The following is a description of a gene set: species: Homo sapiens Human Gene Set: GOBP_POSITIVE_REGULATION_OF_TRANSMEMBRANE_TRANSPORT Any process that activates or increases the frequency, rate or extent of the directed movement of a solute from one side of a membrane to the other., and this is the list of marker genes: LCN2, ABL1, SLC7A5, PLA2G1B, IL13, KCNE5, PSEN1, CAPN10, CRACR2A, CLTRN, RNASEL, ATP1B2, JPH2, XCL1, PPP3R1, C2CD5, HTT, INS, ERFE, EDN1, APPL1, STK39 (serine/threonine kinase 39), IRS2, ACSL5, GRIN1, C3, OPRK1, FGF19, KCNJ2, ARL6IP1, LRRC26, F2R, CD19, STIMATE, P2RX5, CFTR, NR4A3 (NCBI Gene Id 8013), ADIPOQ, OSBPL8, KCNE1, FGF13, AZIN2, NOS1, IFNG, PLCG1, ATP2A1, SLC26A6, CXCL9, CAPN3, CA2, PTPRM, GH1, LRRC52, CREBL2, F2RL3 (F2R like thrombin or trypsin receptor 3), OPN3, F2, NIPSNAP2, BDKRB1, ITGB1 (NCBI Gene Id 3688), SORBS1, MIR1-1, FHL1, FXYD7, ATP1B1, MIR210, ITLN1, ZDHHC7, POU4F2, FXYD5, SLC1A2, WNK3, TOR2A, PPP3CB, EDNRA, CXCL10, ATP1B3, P2RX1, AKAP7, ADCYAP1R1, KLF15, CXCR3, P2RX4, CTSS, RHOQ, PDPK1, FXYD6, TRPC1, NOS1AP (nitric oxide synthase 1 adaptor protein), IGF1, STIM2, AKT2, ARPP19, PPP3CC, CASQ1, IRS1, TRPC3, SNCA, EDN3, HEPH, VMP1, FXYD1, THY1, GPER1, KCNIP2, CLTCL1, CX3CL1, C1QTNF12, ATPSCKMT, P2RX7, TMSB4X, RAP1A, COX17, FXYD4, INSR, ANK2, STAC3, LRRC38, CAV1, PPP3CA, CHP1, AZIN1, KCNH2, CXCL11, MS4A1, SLC17A8, KCNC1, LRRC55, GSTO1, G6PD, CACNB2, GPC3, P2RX2 (purinergic receptor P2X 2), BRAF, MIR223, PRKCI, CACNB3, STAC2, AKT1, FLNA, MIR21, AKAP6, BAX, ACTN4, DRD1 (dopamine receptor D1), KCNC2, APLNR, AMIGO1, ACE2, ANO6, NPPA, ASPH, STAC, BAK1, NTSR1, CEMIP, KCNQ1, ACTN2, FXYD6P3, CD4, TRPC6, AKAP5, P2RX3, PPP3R2, LACRT, SRI, FXYD3, WNK2, SLC34A1, NPSR1, CLIP3, HAP1, OCLN, TESC, ACSL1, TCAF1, SCN1B, FGF21, FXYD2, PTPN11, STIM1, NFE2L2, GRM6, GALR2, P2RY6, GAL, KCNN4, MEF2A, PTH, MAPK14, PIK3R1, TERT